The following is a description of a gene set: species: Homo sapiens Human Gene Set: GOBP_POSITIVE_REGULATION_OF_MULTICELLULAR_ORGANISM_GROWTH Any process that activates or increases the frequency, rate or extent of growth of an organism to reach its usual body size., and this is the list of marker genes: PLS1, PEX5, IGF2, SLC6A3 (NCBI Gene Id 6531), HMGA2, POU3F2, DRD2, MKKS, STAT5A, GHR, GH1, SPTBN4, BBS4, CSF1, FOXS1, PPIB, GPR21, GHRHR, BCL2, CHD7, STAT5B, CREB1, SMO, GHRL, VIL1 (villin 1), BBS2, ATP8A2, DIO3, EZR, NIPBL, GHSR, GHRH, GPAM, HSF1